The following is a description of a gene set: Genes containing one or more binding sites for (Gli3) in their promoter regions (TSS -1000,+100 bp) as identified by GTRD version 20.06 ChIP-seq harmonization. species: Mus musculus from publication Yevshin I, Sharipov R, Kolmykov S, Kondrakhin Y, Kolpakov F (PMID 30445619) Mouse Gene Set: GLI3_TARGET_GENES, and this is the list of marker genes: Ccdc9, Tbccd1, Fbxo25, Ciao1, Rab5b, Snhg8, Rexo4, Sucla2, Gsx1, H2bc26, Pld2, Tmem131, Ermp1, Bhlhb9, Acp6, Ppm1a (NCBI Gene Id 72917), Ift46, Hdlbp, Ciao2b, Ncor2, Ubn2, Nop58, Psmd3, C130026L21Rik, Rnft2, Mm2pr, Arl3, Batf2, Gpd1l, Mau2, Gid8, 4930478K11Rik, Grik2, 1700082M22Rik, Got2, Sct, Pde7a, Kansl1, Irak1bp1, Thg1l, Dhodh, Lrrc59, Mrps15 (mitochondrial ribosomal protein S15), Gm40190, Tdp2, Trmt1, Slc35b3, Brd2, Nemf, Rad23b, 2700062C07Rik, Abr, Slc6a6, Mpz, Chd2, Rps15, Rpl31, Mfsd8, Gm5447, Zgrf1, Gabbr1 (NCBI Gene Id 54393), Shank2, Slc25a16 (solute carrier family 25 (mitochondrial carrier, Graves disease autoantigen), member 16), Rpa3, Tle4, Vps13d, Adam17, Eif4a3, Eed, Dxo, Kcnb1, Pdia5, Itgb3bp, Fam222b, Zfp707, Dcun1d3, Hint3, Atp5if1, Ptch2, Suds3, Grk5, Duxf1, Prdx1, Ganab, Kctd3, Dynlt2b, 1700045H11Rik, Dctn5, Tnfrsf9, 3000002C10Rik (NCBI Gene Id 384982), Glul, Mt1, Dnm2, Camk2n1, Fut11, Zfp787, Cxxc4, Fau, Snord13, Sod1, Tmem132e, Rps14, Clcn4, Entpd6, Tsg101, Coa6, Esco1, Ess2, Litaf, Manf (NCBI Gene Id 74840), Amdhd2, Gpn3, Pink1, Samd13, Srxn1, Gm16876, Tomm40l, Magohb, Hook2, Scpep1, Ptpn13, Gstm1, Dph1, Qtrt1 (queuine tRNA-ribosyltransferase catalytic subunit 1), Nsfl1c, Myef2, Fam216a, Ndrg1, Cog4, Rbbp4, Cdkn2aipnl, C2cd5 (NCBI Gene Id 77314), Srsf2, Eci1, Pxylp1, BC049715, Timmdc1, Tbc1d1, Eif5, Polr1has, Gemin7, Mgat2 (NCBI Gene Id 217665), Lrfn4, Gm13830, Plpbp, Tedc1, Usp21, Dnajc19, Dnal4, Actr3b, Slbp, Katnbl1, Washc2, Mcl1, Snrpc, Eef2, 2900052L18Rik, Med25, Herpud1, Cfap68, Ube2b (NCBI Gene Id 67159), Anks3, 2610005L07Rik, Aar2, Rad54l2, Nabp1, Eif4e2, Ptprr, Xkr6, 2310015A10Rik, Ctnna3, Atxn7l2, Kctd9, Map3k5, 5033403F01Rik, Dennd4b, Dock7, Mrpl14, Tmbim4, Pigp, Errfi1 (NCBI Gene Id 74155), Poldip3, Ap4m1, Cdk5rap1, Gm26608, Men1, Sugp1, Rps6kb2, Ctnnb1, 9530059O14Rik, Mtmr14, Bag6, 1700064H15Rik, Wdr25, 4921507G05Rik (RIKEN cDNA 4921507G05 gene), Dpp3, Usp29, Cct6a, Ppp1r10, Slc30a5, Atg14, Zhx3, A930032L01Rik, Ttc28, Psmg1, Ddx55, Senp8, Oma1, Rab3il1, Champ1, Arnt, Gm10501, Srcin1, Cep120 (NCBI Gene Id 225523), 4930589O11Rik, Jag1, Med23, Cox8a, Cmc2, Arpc5, A830005F24Rik, Cox19, Rgl1, Uhrf2, Lca5l, Unc13a, Dph6, Acot7, Mpp1, Zfp292, Bcl2l11, Marchf2, Acp2, Gsdme, Taco1os, Abtb1, Cep104, Btg1, Minar2, Mtg2, Nme6, Mcm3ap, Mcm7, Ulk3, Cyp39a1, Tcf7l1 (NCBI Gene Id 21415), Dcakd, Klhl10, Mrps18b, Nkapd1, Uba5, Cstf2, Nags, Park7, Supv3l1, Mir7b, Epo, Gnb1l, Gm13425 (NCBI Gene Id 100504258), Mindy1, Rbm17, Ttll4, Snrpd1, Rabggtb, A530072M11Rik, Wdr35 (WD repeat domain 35), Ndufs7, Rcbtb1, Trnau1ap, Thrap3, Cibar2, Gm26513, Tmx4, Emid1, Ints14, Tmem64, Harbi1, Xrcc3, Zswim6, Gatad2a, Zbtb6, Rpl36al, Snx1, Thumpd3, Zfp169, Zfyve21, Khk, Kiz, Eps15, Ccdc59, Ttc3, Ncbp2, Srsf7, Ing1, Tufm, H2ac18, Cilk1, Ccdc38 (NCBI Gene Id 237465), Snora24, Mir5122, Gm24016, Gm28047, Cox15, Rras2, Oacyl, Neurog1, Oxa1l, Prdm8, Syn2, Hdx, Rps15a, Cnot4, Eif4enif1, Taf4, Wbp11, Ube2j2, Aarsd1, Dda1, Gm15564, Ptpn2, Ccdc134, Podxl, Washc1, Tti2, Ccdc142os, Endov, Ppm1e, Ppm1l, Polr1h, Alg9, Sde2, Zbtb48, Ssr2, Iqsec1, Zfp827, Dyrk3 (NCBI Gene Id 226419), Bicdl1, Knl1, Baz2b, Sema6d, Cuedc1, Nup133, Dtwd1, Tcea1, Cdh22, Kansl3, Atg4a, Ncbp2as2, Tmem101, Ppat, Zhx1, 1700003M07Rik, Ssrp1, Ogg1, Rasal1 (RAS protein activator like 1 (GAP1 like)), H1f4, Atg4c, Memo1, Tulp4, Myl12a, Exoc2, Ogt, Rab36, Rbpj, Ppp1r37, Hjurp, Cnp, Hnrnpa0, Bclaf3 (Bclaf1 and Thrap3 family member 3), Fubp3, Atf7, Vgf, Sacm1l, Mapkap1, Zbtb26, Ciz1, Spmip7, Polr2j, Retreg2, Cog2, Hlf, Trip6, Galc, Klhdc4, Nit1, Sigmar1, Commd8, Eif3g, Eef1akmt3, Rnf220, Dnajb11, Lin7c, Wipf2, Ccdc63, Spred1, Ctbp1, Aup1, Sat2, Stxbp5, Tbc1d14, Gm57857, Tmem184b, E2f3, Atp5mj, Dalrd3, Lyrm1, Pafah2, Rbm34, Meaf6, Large1, Adamts1, Telo2, Smad4, 4930524O07Rik, Stpg1, Lrrc8a, Ltbp1, Lss, Tsnax, Cnppd1, Pih1d2, Glra1, Napa, Hadhb, Smim13, U2surp, Gpr156, Tas1r1, Rabgap1, Slc36a1, Pik3r3, Hoxa7, Arhgap44, Atp10d, Ints1, Raf1, Psph, Gdf7, Mettl2, Ostm1, Pnma8a, Ints5, Fancc, Ckap2, Dstyk, Spring1, Frg2f1, Ankle2, Ice2, Tpgs1, Itpr1 (NCBI Gene Id 18544), Rbck1, Spdl1, Dennd2c, Snrnp27, Ccnl1, Ptch1, Lsm2, Grpel2, Zscan22, Irs2, Brpf3, Actr10, Msl2, Dio3, Ric3, Wars1, 4930563E22Rik, Odf2, Rgl2, D5Ertd579e, Prr14l, Slc25a4, Lrp6, Zbtb34, Zfp398, Gadd45g, Tmem119, Ccnd3, Osbpl9, Barhl1 (BarH like homeobox 1), Nnat, Mir5627 (NCBI Gene Id 100885842), Zbtb8os, Tenm4, Faf1, Nubp1, Zfp641, Brca2, P2rx3, Gm13783, D330041H03Rik, Naf1, Mon2, Odr4, Snhg6, Plxna3, Gm15612, Slc25a27, Mkx, Slit3, Vps25, Pds5b, Stat1, Pik3r2 (phosphoinositide-3-kinase regulatory subunit 2), Taf13, Fam3a, Txndc17, Gm10614, Hpca, Ptk2 (NCBI Gene Id 14083), Acot13, Hoxaas2, Dtd1, Tspan15, Fam53c, Pah (NCBI Gene Id 18478), Uvssa, Ilf2, Uggt2, Ndufa9, Bfsp1, Ddx51, Cacng2 (NCBI Gene Id 77978), Fancm, Efcab2, Nfxl1, Plxnb1, Cdiptos, Gm12279, Tmem63b, Vps18, Fam227b, Sfxn2, 2010320M18Rik, Nnt, Calm3, Gm43403, Ocel1, Wdr36, Ergic1, Hnrnpr, Cenpu, Wwc2, Prdm13, Mtpap, Atxn2, Ass1, Nrf1, Car7, Ensa, Tfrc, Tamm41, Nefl, Hps3, Cenatac, Atg13, Armc8, Palld, Myo9a, Sprtn, Mapkbp1, Ddah2, 6030458C11Rik, Golga4, Scarb1, Slc9a1, Zfp2, 1810044D09Rik, Trmo, Por, Umad1, Patz1, Atad2b, Ttll11, N4bp2l2, Stau2, Dazap2, Gm11175, Usp35, A830082K12Rik, A730020E08Rik (RIKEN cDNA A730020E08 gene), Neo1, Tmem121b, 1700041G16Rik, Eif3e, Necap2, Clcn2, Pfdn2, Map2k7, Bud13, Mrpl9, Uck1, Ostc, Pitrm1, Cln5, Nfu1, Cdca2, Smim14, Tank, Nol9, Nhlrc1, Gm22973, Lrp12 (NCBI Gene Id 239393), Tfb2m, Paics, Marchf7, Rab34, Teddm2, Tomm70a, Tomm20, Mfsd5, Cgn, A430005L14Rik, Dicer1, Gm16283, Slc16a9, Ephb3, Pisd, Cacnb4, Lztfl1, Fam117b, Tmem127, Mtcl1, Nr1d2, Tbc1d24, Zfp11, Ndrg3, Polr3a, Abhd18, Dpysl2, D330050G23Rik, Zfand2a, Hexd, Uspl1, Rufy1, Zfp866, Larp7, Hadha, H4c6, Rnu12, Gm20033, Tmem70, Ppil4, Hes1, Rtf1, Senp1, Insig1, Ubiad1, Abcb7, Nt5dc3, C330013E15Rik, Kdm1a, Cdc73, Edf1, Stk19, Gins2, Ciao3, Dusp11, Nr1h3, Tpr, Selenot, Manba, Eif2b1, Scn2a (sodium channel, voltage-gated, type II, alpha), Lonrf1, Gm6884, Hoxa2, Ulk2, Alad, Gm19265, Hsd17b12, Zfp882, 4930583K01Rik, Lap3, Phospho1, Crbn, Csnk2a2, Atp6v0e, Atl2, Rasgef1b, Leprotl1, Cenpn, Htra2, Gtf2h3, Cfap251, H4c3, Gnai2, Mettl25, Mitd1, Doc2a, Tmem74, Lrrc1, Slc25a53, Cyb5r1, Ankrd13a, Cbx5, Taf11, Zcchc4, Nacc1, Cebpa, Map4, Specc1, Tafa5, Dnajb9, Gm17690, Lmnb2, Lsm7, Igf1, Dohh, Tbl1x, Cnpy4 (canopy FGF signaling regulator 4), Acad11, Dnai1, Ufl1, Fam8a1, Palb2, Sik3, 1500015A07Rik, Znrf1, Morf4l1, Cmtr2, Gramd1b (GRAM domain containing 1B), B230219D22Rik, Psmb3, Rab3gap2, Cutc, Usp49, Exoc8, Taf6, Pde4c, Mfsd11 (major facilitator superfamily domain containing 11), Ercc6l2, Ngrn, Zfp148, Fut10, Mapk7 (mitogen-activated protein kinase 7), Amdhd1, Usp16, Cfap100, Irak3, Mettl1, Atg5, Pelp1, Srcap, 1700057H15Rik, Dleu7, Nae1, Zfp105, Rgcc, Rflna, Cdipt, Ttc39d, Hdgf, Cnr1 (cannabinoid receptor 1), Foxj3, Copz1, Snord45c, Ube2g2, Gm15743, Ipo13, Sf3b3, Spns1, Gm17733, Med4, Mir219a-1, Arid1a, Sdcbp (NCBI Gene Id 53378), Hmgn1, Zfyve16, Sgms2, 4933427D14Rik, Jmjd8, Pnrc2, Iqce, Hsp90ab1, Spsb1, Smchd1, Exo5, Snx12, Nr1h2, Lrpap1, H3c7, Nt5c3b, Zc3h10, Ncln, Gm16853, Ppp1r9b, Ist1, Dmac1, Arid5a, Serac1, Marchf8, Rbm15b, Zbtb14, Trpm8, Has2, Tmod3, Mir3067, Dtwd2, Usp2, Unk, Gprin1, Frat2, Efcab7, Scrt1, Fyttd1 (forty-two-three domain containing 1), Sppl2b, Rai1, Gm19569, Auts2, Hes6, Jam2, Rhd, Ikbkg, Sf3b4, Tex14, Rubcn, Ddx19b, Cfap97, Ubb, Blcap, Mrpl49, Naa16, Cdk4, Mrpl53, Faf2, Ctdspl2, Gtf2h5, Tceanc, Trpc7, Nell2, Gcat, Dcaf8 (NCBI Gene Id 98534), Naxd, Mgat5b, Cnst, Srrm3, Mat2a, 4921531C22Rik, AI854703, Fbxo33, Spg11, Ube4a, Nlgn3, Ptdss2, Psmd10, Ndufc2, Med31, Mbtps2, Odad4, Trps1, Rps20, Ccdc30, 1110018N20Rik, Commd2, Ephb2, Fzd7, Crebzf, Dhcr24, Foxo6, Glod4, Prkag1, H2az1, Rnps1, Gnb2, Drosha, Gm4117, Pgm2l1, Noc4l, Nr4a3, Mageb3, Mxi1, Fabp7, Dynll1, Shprh, Tmem168, Aprt, Taf1c, Csnk1d, Hic2, Dido1, Mrm3, 1700007L15Rik, Mir9-3hg, Fbxw7, Rbm25, Tpd52l1, Necab2, Pcm1, Hspa8, 2810039B14Rik, Gm9951, Gse1, Septin2, Prmt5, Fgd3, Suz12, Ppfibp1, Junb, Ginm1, Mrpl30, Sema6a, Eef1akmt2, Psen1, Spata24, Mettl21a, Ccdc57, Timm9, Cdc25a (cell division cycle 25A), Peg3, 9030622O22Rik, Top1mt, Srebf1, Grb10, Asnsd1, Elac2, Mrps33, Limk2 (LIM domain kinase 2), Maml3, Acsl1, Ndufs8, Zfp109, Eeig1, Dynlt1b